The following is a description of a gene set: This event has been computationally inferred from an event that has been demonstrated in another species.<p>The inference is based on the homology mapping from PANTHER. Briefly, reactions for which all involved PhysicalEntities (in input, output and catalyst) have a mapped orthologue/paralogue (for complexes at least 75% of components must have a mapping) are inferred to the other species. electronically inferred by orthology from the curated human pathway part of: Resolution of Abasic Sites (AP sites) Reactome Pathway: APEX1-Independent Resolution of AP Sites via the Single Nucleotide Replacement Pathway species: Mus musculus, and this is the list of marker genes: Neil2, Ogg1, Xrcc1, Neil1